Given this list of marker genes Gab1, Il10, Vil1, Appl1, Casr, Gclc, Crk, Nrp1, Bcar1, Med1, Crebbp, Appl2 (NCBI Gene Id 216190), Creb1, Rela, Hgf, Il6, Gsk3b (glycogen synthase kinase 3 beta), Lgmn, Gclm, Adamts12, here is a description of the gene set: Mouse Gene Set: GOBP_RESPONSE_TO_HEPATOCYTE_GROWTH_FACTOR Any process that results in a change in state or activity of a cell or an organism (in terms of movement, secretion, enzyme production, gene expression, etc.) as a result of a hepatocyte growth factor stimulus. species: Mus musculus